Given this list of marker genes GOT1, PCK2, PGP, LEP, PCK1, here is a description of the gene set: The chemical reactions and pathways resulting in the formation of alditols, any polyhydric alcohol derived from the acyclic form of a monosaccharide by reduction of its aldehyde or keto group to an alcoholic group. studied in species Homo sapiens Human Gene Set: GOBP_ALDITOL_BIOSYNTHETIC_PROCESS